The following is a description of a gene set: Postnatal macrocephaly species: Homo sapiens Human Gene Set: HP_POSTNATAL_MACROCEPHALY The postnatal development of an abnormally large skull (macrocephaly)., and this is the list of marker genes: FAM111A (NCBI Gene Id 63901), PTEN, MED12, GNB1, SETD2, PAK1